The following is a description of a gene set: studied in species Mus musculus A process that is carried out at the cellular level which results in the assembly, arrangement of constituent parts, or disassembly of a postsynapse. Mouse Gene Set: GOBP_POSTSYNAPSE_ORGANIZATION, and this is the list of marker genes: Mark2, Dock1, Csmd2, Abi2, Cc2d1a, Itga3, Srcin1, Dbn1, Numbl, Lrfn1, Asap1, Ptn (NCBI Gene Id 19242), S1pr2, Hnrnpk, Xlr3b, Cbln1, Cntnap2, Arhgap33, Cnksr2, Efna1, C1ql3, Lrrc4, Dvl1, Frrs1l, Lrp8, Musk, Nae1, Flrt2 (fibronectin leucine rich transmembrane protein 2), Nedd9, Rac1, Wasl, Srgap3, Dgkz, Rapsn, Ephb1, Chrdl1, Pdlim5, Mtmr2, Cpne6, Lzts1, Cadm1 (cell adhesion molecule 1), Myh10, Fcgr2b, Kif2c, Grin2b, Sorbs2, Apoe, Hnrnpm, Epha7, Shisa7, Farp1, Arhgap22, Mfn1, Frmpd4, Ghsr, Arf1, Tsc2, Actb, Ptprs, Sh3gl2, Gap43 (growth associated protein 43), Il1rap, Lats1, Grid2, Ube2m, Dlg5, Eef2k, Ppp1r9a (NCBI Gene Id 72734), Grip2, Arc, Magi2, Usp9x, Numb, Rbmx, Sigmar1 (sigma non-opioid intracellular receptor 1), Lhfpl4 (lipoma HMGIC fusion partner-like protein 4), Chrnb1, Fam107a, Homer1, Akt1, Arf6, Marcks, Reln, Trim47, Ephb3, Gphn, Ptprf, Ntrk3, Htr4, Dlg1, Lrrtm2, Abhd17a, Shank3, Asic2 (NCBI Gene Id 637557), Igf1r (insulin-like growth factor I receptor), Ephb2, Myo9a, Lrfn4, Nptxr, Caprin2, Ngef, Baiap2, Shisa6, Slc12a5, Actn2, Syngap1, Arhgef9, Nedd8 (NCBI Gene Id 18002), Cdh2, Fnta, Nrxn3, Nlgn2, Disc1, Wnt7a, Iqgap1, Rps6ka5, Lzts3, Psen1, Cdk5, Zdhhc15, Lrrtm4, Slc7a11, Nrcam, Prmt3, Gna13 (NCBI Gene Id 14674), Dgkb, Mesd, Caprin1, Psen2, App (amyloid beta precursor protein), Rheb, Lrfn2, Xlr4b, Crkl (NCBI Gene Id 68624), Cdk5r1, Dbnl, Zmynd8 (NCBI Gene Id 99150), Tmem108, Adgrb1, Epha4, Lrrtm1, Dock7, Actn1, Ins2, Pick1, Psd, Lama5, Ssh1, Iqsec3, Ntng2, Lrp5, Cript, Rac3 (NCBI Gene Id 170758), Zdhhc2, Dip2a, Pafah1b1, Cttn, Grid1, Dlg2, Ins1, Cyfip2, Syndig1, Dok7, Slitrk3, Mpp2, Arhgef7, Nectin3, Rph3a, Grin1, Insr, Pak3, Bhlhb9, Septin7, Dnaja3, Abhd17c, Prickle1, Il1rapl1, Asic1, Dock10, Chrna7, Vps35, Dnm1l, Ncan, Ctnnd2, Xlr4a, Nrp1, Pten, Neurl1a, Glrb, Lrp4, Tiam1, Itgb3, Mfn2, Ina (NCBI Gene Id 329069), Ghrl (NCBI Gene Id 80454), Carmil3, Ube3a, Hspa8, Wnt5a, Ppp1r9b, Sipa1l1, Nf1, Arhgef15, Taok2, Elmo1, Slc30a1, Camk2b, Itsn1, Nptx1, Nrxn1, Sorbs1, Dtnbp1, Kif1a, Crmp1, Nlgn1, Actr2, Abi3bp, Fyn, Rock2, Zdhhc12, Ppfia2, Actr3, Chmp2b, Pum2, Sema4c, Lgmn, Stk38, Colq, Ror2, Snx27, Nlgn3, Ptpn1, Ube3b, Dhx36, Dlg4, Abhd17b, Epha5, Rtn4, Trem2, Stau2, Myo5b, Rer1, Sema3f, Dnm3, Fgfr1, Insyn1, Crk, Nckipsd, Arhgap44, Kalrn, Shank2, Dock4, Rtn4r, Dclk1, Cdc42, Vhl, Map1b, Tanc2, Nrp2, Caskin1, Ophn1, Cask, Lrrk2, Itpka, Nrxn2, C1ql2 (NCBI Gene Id 226359), Hdac6, Rhog, Cfl1, Grin2a, Abi3, Ptk2b, Cdkl5, Abl2, Hip1r, Stk38l, Nefl, Etv5, Tanc1, Prnp, Mark1, Zfp804a, Cit, Itgb1, Rapgef4, Prickle2, Fzd9, Nos1ap, Sptbn2, Cux2, Gdnf, Afdn, Abl1, Cpeb3, Dcx, Ckap5, Adam10, Shank1, Nefh, Dact1 (NCBI Gene Id 66738), Arf4 (NCBI Gene Id 30916), Arhgap39, Zdhhc8, Adgrl3, Wasf2, Agrn, Opa1, Zfp365, Ezr, Cntnap1, Ptprd, Htr1a, Plppr4, Lrrc4b